The following is a description of a gene set: Human Gene Set: HP_JAW_HYPERREFLEXIA Increased intensity of muscle tendon reflexes in jaw. species: Homo sapiens Jaw hyperreflexia, and this is the list of marker genes: CHCHD10, MATR3, SOD1, CFAP410, DAO, TBK1, ANXA11, UBQLN2, UNC13A, ITPR1, FIG4, OPTN, NEK1, ANG, TREM2, AP4M1, GLE1, FUS, VAPB, SQSTM1, SPG21, PON1, TARDBP, HNRNPA1, PRPH, GLT8D1 (glycosyltransferase 8 domain containing 1), DCTN1, GCH1, ATXN2, PON2, NEFH, PPARGC1A, TAF15, PON3, SPTLC1 (serine palmitoyltransferase long chain base subunit 1), ERBB4, CCNF, VCP, NRCAM, PFN1, CHMP2B